Given this list of marker genes 4930447C04Rik, Spin1, Anapc5, Nfia, Banf1, Cdt1, Mei4, Tubg1, Terf1, Cdc14b, Met, Klhl22, Npm2, Ralbp1, Ncaph, Bub1b (BUB1B, mitotic checkpoint serine/threonine kinase), Chmp2a, Hoxa13, Birc5, Bub3, Anapc15, Ndc80, Bmp7, Ncapd2, Brip1, Chmp3 (NCBI Gene Id 66820), Spag5, Fzr1, Fgf8, Cenpk, Pgam5, Ercc4, Igf1, Prickle1, Mos, Cenpc1, Cdk1, Cep63, Nup62 (nucleoporin 62), Rbm46, Eme1, Top2a, Smarca5, Anapc7, Rad54b, Phb2, Majin, Chmp7, Map9, Eml3, Stra8, Misp, Bag6, Orc4, Vps4a, Klhdc8b, Mastl, Reep4, Spice1, Tmcc1 (NCBI Gene Id 330401, transmembrane and coiled coil domains 1), Cep97, Mtfr1l, Kif18b, Rad51c, Kpnb1, Ins1, Nipbl, Ereg, Dazl, Rad51ap1, Fmn2, Ccne2, Dusp1, Myo19, Hormad1, Spdl1, Acot8, Rspo1, Fbxo5, Msx2, Psrc1, Mfn1, Sycp3, Ucp2, Calr, Cdkn1c, Edn3, Ankrd53, Acox1, Ppargc1a, Chtf18, Vps4b, Map10 (microtubule-associated protein 10), Pten (NCBI Gene Id 70161), Rpl10l, Arhgef10, Meiob, Ccne1, Meikin, Smc2, Neurog1, Cenpi, Edn1, Rad51d, Gpr3, Ik, Becn1 (beclin 1, autophagy related), Hsf2bp, Kif3b, Fignl1, Trim75, Fancm, Ranbp1, Ooep, Rala, Xrcc3, Igf2, Sirt1, Ubb, Bccip, Gja1, Spast, Nsfl1c, Pcid2, Atf6b, Syce3, Psmc3ip, Ddx4, Mlh3, Brme1, Smc4, Nme6, Aspm, Cul3, Nsl1, Rcc1, Dis3l2, Igf1r, Pex19, Pde3a, Ubr2, Wrap73, Tmem135, Cntd1, Washc1, Cul9, Msx1, Spire2, Septin1, Ttk, Abraxas2, Ccnb1, Seh1l, Cenpe, Cyp26b1, Hsf1, Igtp, Zfy2 (NCBI Gene Id 22768), Knl1, Ccnb1-ps, L3mbtl1, Ins2, Rnf212, Cdca8, Hnrnpu (heterogeneous nuclear ribonucleoprotein U), Wee2, Mlh1, Sycp1, Pink1, Spdya, Brca2, Btc, Cks2, Cd28, Bmp4, Nanos2, Suv39h2, Mapre1, Sirt2, Cdc25b, Ska1, Pex11a, Nde1, Tdrd9, Cox10, Obsl1, Vps35, Mfn2, Opa1, Stag1, Mybl1, Dmrtc2 (doublesex and mab-3 related transcription factor like family C2), Cep192, Msh5, Mei1, Katnb1, Mus81, Mtbp, Spire1, Rmi1, Fgfr2, Hspa1b, Inf2, Tubg2, Khdc3, Sec16b, Prdm9, Spata22, Golga2, Apc, Chfr, Mcu (NCBI Gene Id 69874), Plk1, Phip, Snhg15, Spc25, Psma8, Mov10l1 (NCBI Gene Id 83456), Marchf5, Ccsap, Rad1, Bnip3, Kif2a, Mybl2, Cdc23, Syce1l, Gsk3b, Sphk1, Mtfr1, Ddhd2 (NCBI Gene Id 72108), Mul1, Kif14, Ube2s, Mis12, Ppp2r2d, Aurkb, Lif, Pnma5, Insr, Chmp5, Dhodh, Racgap1, Tgfa, Cdc42, Nudc, Bora, Mnd1, Akap8, Cep85, Cdk11b, Ywhah, Hfm1, Chmp1b2, Eps8, Chmp4b, Pdgfb, Terb1, Dcn, Mff, Anapc15-ps, Piwil2, Ing2, Smc3, Mad2l1, Ago4, Fis1, Pparg, Zwint, Syce2, Nfib, Lpin1, Wapl, Kash5, Ncaph2, Ran, Sgo1, Irgm1, Brox, Tpr (NCBI Gene Id 74816), Pinx1, Eme2, Slc25a46, Cul7, Lrp5, Akap8l, Zw10, Pdgfrb, Nuf2, Mief2, Tpx2, Mir539, Lcmt1, Ubxn2b (UBX domain protein 2B), Tom1l2, Pex11b, Rnf212b, Psmd13, Hspa1a (heat shock protein 1A), Prap1, Rpl24, Npr2, Usp16, Poldip2, Champ1 (chromosome alignment maintaining phosphoprotein 1), Ccdc8, Bcl2l11, Kntc1, Kat5, Fancd2, Ofd1, Esr1, Cdca5, Kat2b, Iho1, Fbxw5, Ppp2r1a, Morc2b, Rad51, Ska2, Ube2b, Shcbp1l, Dmc1, Ube2c, Washc5, Top2b, Rb1 (NCBI Gene Id 19645), Foxj2, Mir361, Mre11a, Kif4, Phf13, Ddb1, Osm, Ctdp1, Cdc16, Rab11a, Dync1li1, Anapc11, Gen1, Tdrd12, Mael, Incenp, Cenps, Fbxo43, Siah1a, Cdc14a, Ppp2r2b, Brdt, Ino80, Nsmce2, Ddhd1, ENSMUSG00000126352, M1ap, Ehmt2, Cenpx, Zfp541, Shoc1, Numa1, Hspa2, Ripor2, Asz1, Zfp207, Tom1l1, Tesmin, Cdk5rap2, Mzt1, Prpf4b, Actr3, Reep3, Drd3, Nfe2l1, Spo11, Ska3, Rad21, BC005624, Chek2, Knstrn, Chmp1b, Dnm1l, Rad21l, Dmrt1, Chmp4c, Chmp2b (NCBI Gene Id 68942), Mir124a-3, Chek1, Pibf1, Pebp1, Kif22, Baz1b, Sun1, Kif23, Atm, Trip13, Lsm14a, Cit, Ncapd3, Smc1a, Mapk15, Rps6ka2, Cdkn1b, Ube2srt, Ankle1, Dctn2, Aaas, Sycp2, Coro1c, Tdrkh, Kctd19, Cpeb1, Nek2 (NIMA (never in mitosis gene a)-related expressed kinase 2), Uhrf1, Rangrf, Pex11g, Zcwpw1, Kif18a, Marf1, Wnt5a, Terb2, Slc25a31 (NCBI Gene Id 73333), Haspin, Mapt, Nusap1, Stag3, Prkn, Clasp2, Cav2 (NCBI Gene Id 12390), Stat2, Ccnb1ip1, Wnt4 (wingless-type MMTV integration site family, member 4), Rgcc, Ndel1, Topbp1, Ccdc66, Kif15, Tex15, Clasp1, Ankrd31, Kifc1, Pdxp, Kif2c, Cdca2, Aurka, Zwilch, Rrs1, Dnmt3l, Eif4g3, Mir124a-1, Gdap1, Ap3b1, Mad2l1bp, Kdr, Syde1, Mki67, Slx4, Foxj3, Tex14, Fgfr3, Egf, Mtfr2, Meioc, Epgn, Sh2b1, Smpd3, 4930550C14Rik, Chmp1a, Espl1, Tex19.2, Il1b, Bend2, Kif11, Ccnb2, Cyrib, Abraxas1, Irgm2, Sgo2a, Rad54l, Msh4, Dcaf13, Rec8, Mcmdc2, Eml4, Stag2, Psmg2, Top6bl, Ndc1, Zscan21, Tgfb1, Tex19.1, Sirt7, Ggnbp1, Rhoa, Ncapg, Chmp6, Plcb1 (NCBI Gene Id 98861), Arhgap33os (Rho GTPase activating protein 33, opposite strand), Bub1, Camk2b, Drg1, Usp44, Btbd18, Ncapg2, Hsf5, Cltc (NCBI Gene Id 97762), Meiosin, Syce1, Tex11, Tex12, Ccdc61, Mief1, Mad1l1, Pttg1, Flna, Prc1, Catsperz, Mtch2, 1700028K03Rik, Spc24, Tnf, Kifc5b, Nfix, Carlr, Fanca, Il1a, Mtfp1, Actr2, Mir124a-2, Cdc20, Ankle2, here is a description of the gene set: species: Mus musculus Mouse Gene Set: GOBP_ORGANELLE_FISSION The creation of two or more organelles by division of one organelle.